Given this list of marker genes Sptan1, Tpm3, Ccp110, Dst, Sh3rf1, Dlg5, Peak1, Pak4, Txnl1, Git2, Nck1, Depdc1b, Arhgap12, Pik3r1, Cep97, Rhov, Nck2, Arhgef7, Iqgap1, Wdr6, Pak2, Myo9a, Cdc42, Cltc, Pak6, Sptbn1, Tpm4, Epha2, Usp9x, Map3k11, Zfp512b, Pard6a, Pak1, Git1 (NCBI Gene Id 63992), Pard6b, Vangl1, here is a description of the gene set: species: Mus musculus RHOV GTPase cycle Mouse Gene Set: REACTOME_RHOV_GTPASE_CYCLE